The following is a description of a gene set: A condition characterized by a loss or deficiency of the stem cells in the limbus that are vital for re-population of the corneal epithelium and to the barrier function of the limbus. Limbal stem cell deficiency species: Homo sapiens Human Gene Set: HP_LIMBAL_STEM_CELL_DEFICIENCY, and this is the list of marker genes: FGFR2 (NCBI Gene Id 2263), GJB2, GJB6, FGFR3, FOXC1, FGF10, DDR2, PAX6, TRIM44, NLRP1